Given this list of marker genes Syt13, Syt1, Prrt2, Doc2g, Cacna1b, Rph3al, Anxa1 (NCBI Gene Id 319730), Rims1, Doc2b, C2cd5, Syt11, Rimbp2, Erc1, Erc2, Znrf2, Rph3a, Rims2, Pla2g4a, Znrf1, Syt4, Syt3, Syt5, Anxa2, Kif5b, Syt8, Doc2a, Syt7, Syt9 (synaptotagmin IX), Syt2, Snca (NCBI Gene Id 20617), here is a description of the gene set: studied in species Mus musculus Any process that activates or increases the frequency, rate or extent of vesicle fusion. Mouse Gene Set: GOBP_POSITIVE_REGULATION_OF_VESICLE_FUSION